Given this list of marker genes HADH, DNMT3B, SYTL1, ZC3H15, DIAPH1, WBP4, ANKRD36, ZFAND3-DT, MIB1, PGGHG, ZNF512B, OTUD4, EEF1DP3, TMEM134, KLHL5, DVL1, PRKAR1B-AS1, AGFG2 (NCBI Gene Id 3268), PPP1R13B-DT, LMO4, ATP2B1 (ATPase plasma membrane Ca2+ transporting 1), USP3, ANKH-DT, C8G, RERE, LINC01686, CHAF1B, TMEM131, SLC66A2, TPTEP2, MSL3-DT, FBXO41, KCTD13, NKTR, FBXO6, KCNMB4, RAC1, ZBTB7A, ALAD, GTF2H5, KIFC3, SPATA20, ACADM, ARL3 (NCBI Gene Id 403), ZYX, NSD3, DMAC2L, NELFB, NFE2L2, STYX, FCHSD2, TP53BP1, IP6K1, FAM120AOS, CHMP4B, TRAPPC8, VARS1, ACTR10, RASSF1, CHCT1, ORAI1, DRAM1, PDIA6, SPOPL, NAB1, ARHGAP31-AS1, EFHC1, IFNGR2, SEPTIN7, NFATC1, TRIB1, LYRM1, N4BP2L1, KLF2-DT, HIF1A, LMAN1, ANKEF1, POFUT1, CCDC42, PGK1, BTBD1, GSK3B, METTL25B, GLUD1, UBXN1, CDK13-DT, POLD3, SH3BP1, IER3-AS1, CISD3, DGKD, STX4, NQO2, KEAP1, BMP2K-DT, FBXW8, EPS8L2, SOCS5, BNIP2, CRAMP1, PDGFA, RCN2, SMAD3, AP2B1, ATP2A2, TIGD1 (NCBI Gene Id 200765), SLCO4A1, ERO1A, PIGX, CHCHD7 (coiled-coil-helix-coiled-coil-helix domain containing 7), UPP1 (uridine phosphorylase 1), PKMYT1, PANK2-AS1, SH3GLB2, PFN4, LINC01116, TFAM (transcription factor A, mitochondrial), FDX1, INTS11, KRI1 (NCBI Gene Id 65095), DGLUCY (D-glutamate cyclase), NDUFV3, MED9, MICAL1, ORAI2, TIMP1, FNDC3A, DAP, MYADM, PHRF1, PTGES3, TNFSF14, ZNF330, PHF13, RBPJ, ZNF524, RBFOX2, ANTKMT, TVP23C, SNX8, RIC1, ENSG00000233230, LRP3, COL7A1, TXLNA, PPP1R18, DCUN1D3 (defective in cullin neddylation 1 domain containing 3), CAMSAP1, EBPL, SNAP29, POU2F2, FAM131B-AS2, TLK1, NUP43, TWSG1-DT, ZCCHC24, CEBPA, ATAD2B, CREB5, RNF187, TRIOBP, IQCG, TRG-AS1 (T cell receptor gamma locus antisense RNA 1), COA7, SCN8A, CDNF, MIR142HG (NCBI Gene Id 123466215), RAD52, B3GALNT2, PPP3CB-AS1, CHST12 (carbohydrate sulfotransferase 12), HEXIM1, C8orf33, PPP1CA, GPX4, ILRUN-AS1, ZNF488, ORC4, STK35, PLEC, GTF2IRD2B, CPLX1, RABGEF1, KLF10, RRAGC-DT, TMSB10, ELMO2, CLN6, GTF2E2, LAMP1, PIAS2, QSER1, RGCC, CDKN2B-AS1, ACO1, CCDC34, EEPD1, CACNA2D1, SETD5, DCAF7, SMURF2, BRCC3, ANLN, MIR378D2HG, GABPA, SMIM14, KDM5B, TDRD3 (tudor domain containing 3), XPO6, SMAD3-DT, ANXA7, GATAD2B, FAM118A, RSRC1, LIPT2-AS1, SIAH2, SLC35B2, MIER1, THRAP3, TADA3, KATNAL2, OGFOD3, LIMD2, TMCO3, TRADD, FAR1, DPYD, TOM1, HEBP2, HPCAL1, PDZD8, USP28, TENT5C-DT, FOXJ3 (forkhead box J3), KDM7A, KBTBD7, LRRFIP1, EXOC3-AS1 (NCBI Gene Id 116349), CYP2U1, SLC16A3, N4BP3, TENT5C, S100A10, CCT6P3, DYRK3, PSMD13, SPSB1 (NCBI Gene Id 80176), AFF4-DT, HSPA8, DAZAP1, MBOAT7, IGF2BP3, ILRUN, APLP1, SRF, DNAAF9, SLC9A3-OT1, ZNF740, CORO2A, DENND4A, USP12, DNAI4, EPS15, PTPRE, USP32, BCL9, METTL25, CCND1 (cyclin D1), MRPL51, INTS4, USP42 (NCBI Gene Id 84132), FRAT2, STAT1, NR1D2, PHF19, CREBL2 (cAMP responsive element binding protein like 2), DCAF11, PARK7, DNM1L, TPI1, MED14, CEP83-DT, PTPRA, GOLGA2, RAB8B, MIR4710, COPRS, GCLC, EEF1A1, UBE2Z, MPO, TMEM139-AS1, LRFN4, IREB2, NFKBIE, ZC3H14, CYP20A1, DUSP2, LIPT2, URB2, ARHGAP12, AHNAK, SH3GL1, BRF1, ABI2, QSOX2, ZMYM2, TMEM52, MYADM-AS1, CCND3, TLE5, HVCN1, FABP5P3, SLCO4C1, CCNT2, PHF7 (NCBI Gene Id 51533), PPP1R3E (protein phosphatase 1 regulatory subunit 3E), RERE-AS1, LINC01703, SRD5A1, CDK19, KPNA1, RAB35, EFEMP2, ENTPD6, COX5A, ARMH4, ANP32A, ARPC5L, ZNF654 (zinc finger protein 654), PSMD2, GNPNAT1, PTPN11, LYL1, TBC1D1, C9orf72, NUDT14, ITGB1, YES1, NRARP, MDK, TVP23C-CDRT4, PTGES2-AS1, LPP-AS2, EEA1 (early endosome antigen 1), SNAPC2, SENP6, ZNRF1, RIN3, PLEKHO2, PLEKHF2, HDAC5, ZNF425, SLC20A1-DT, ZNF557, USP38-DT, SNHG4, HMGA1, STK32C, CEBPB, SQLE, HACD1, MALT1, LINC03100, TDRD7 (NCBI Gene Id 23424), GXYLT1 (NCBI Gene Id 338841), PGP, SPTAN1, MTCP1, TBKBP1, MIR3181, PAK4, RHEB, MINDY2-DT, SLC23A2, METTL21A, MIR760, DENND5B-AS1, SET, ANKRD17-DT, SACS, GNAQ, PRKD3, FBXO45, ERI2, SFXN3, IMPDH2, DCUN1D2, NUDT3, LACTB2-AS1, GSDMA, SLC9A5, THUMPD3-AS1, ADAM15, CEMIP2 (cell migration inducing hyaluronidase 2), TPT1-AS1, ATP1A1, PRRC2A, CKB, DENND1B, MIR4479, GSTO1, TCP11L2, ERBIN-DT, DNAJB6, SPRY2, LHB (luteinizing hormone subunit beta), TCFL5, ATP5PD, BTG1, TGIF1, LMBR1, KMT5B (lysine methyltransferase 5B), RCAN3, ZNF395, SMIM14-DT, TMEM117, MAFF (NCBI Gene Id 23764), BBC3, ZDHHC17, NR3C1, MPP1, KCNK5, SETX, ERGIC1, PLIN3, BRD2, SLC48A1, DEGS1, SH2D3C, SYNGAP1, NREP, ZBTB1, ARRDC2, LRRC8B, BRAF, CMTM7 (NCBI Gene Id 112616), PUS7 (NCBI Gene Id 54517), DDI2, APPBP2, FZD2, NUDT4, METRNL, KBTBD2, PRPF4, SERGEF, SIVA1, RBM26-AS1, RMND5A, LINC01117, PTH2R, SEPTIN7-DT, FHIP2A, TFE3, SLC35E4, ZNF592, SPOPL-DT, TBCD, TRAM2, SPHK1, HNRNPL, CDK14, SYP, AKIRIN2, GTDC1, NHERF2, PCNT, MANEAL, BMP2K, HSPA14, TSEN34 (NCBI Gene Id 79042), CAMSAP2, SRR, PPP2R5A, CORO1B, ERLIN1, RICTOR, RNF19A, ARFGAP3, TBC1D13, GALNT1 (NCBI Gene Id 2589), GNG10, PDHA1, NXT1, SAMM50, PTGES2, FOXO6, MAP3K20, DYRK3-AS1, B3GNTL1, GSTA4, ECI2, MXRA7, HIC1, BCAP31, GSKIP, CNDP2, HLCS, MED22, KCTD7, ECE1, ZNF213, SLC36A4, FUOM, ENSG00000187186, NUP214, FJX1, IL13RA1, DONSON, PLEKHA3, RNF2, GADD45B, GM2A, MPG, MOCS2, H3-3A-DT, MPC1, C21orf58, MOSPD2, PER1, TRAM2-AS1, SLC2A1-DT, RAB39A, PJA2, PRPF39, CYLD, STAP2, F3, FPGT-TNNI3K, APH1B, NR2F6, PMPCA, GANAB, PTGS1, HSD17B6, LINC02918, ETS2, GPC1, CSRNP1, THAP2, ADGRG6, CENPN (centromere protein N), BZW1-AS1, ENSG00000277020, FAAP20, SNX33, GFER, LASP1 (LIM and SH3 protein 1), ASMTL, FZD5, CCNY, PDP1, SUN2, ATP5PF, MAP4K5, YWHAB, RPL7A, RN7SL254P, PIK3R1, UBXN2A, SMTN, ABHD6, SLC9A8, PURB, CEP112, GCLM, ELK1, VEGFA, ARFGEF2, ZNF341-AS1, ATP6V0A2, RPUSD1, FAM86FP, ATRN, LMNTD2, SF1-DT, NANOS3, GRAMD1A, XPO1, PRIM1, CBFB, TRIM62, SERAC1, SP1, GJA3, TIMM21, RHOG, DEPDC5, DLG4, OSBPL2, FUT11, PTBP2, TMEM123-DT, MIB2, RAB8A, GNB1-DT, ARMC2, PRKAG2-AS1, PLAGL2, TBC1D10A, CCDC91, ANKRD17, FAM174C, ALDH3A2, SMARCD2, SCAF8, PANK2, FAM47E, SLC1A4, RASSF8, PPFIA3, DGKE, KRCC1, CFD, VAPA, LINC00327, NAB2, CDK9, HHEX, MINDY2 (MINDY lysine 48 deubiquitinase 2), MICU1, MIR29B2CHG, NCR3LG1, ANKMY2, ENSG00000228395, PARP6 (NCBI Gene Id 56966), ST3GAL5, SSBP3, TAF6L, SQLE-DT, DSTYK, MBD5, REX1BD, REL, HTATSF1, TRIM44, CREBRF, SMG1P3, ARRDC1, PLBD2, SOS1, UBE2Q2, FMNL3, HOOK3, STAMBPL1, CDYL, TMEM170B, STARD9 (StAR related lipid transfer domain containing 9), EIF4H, VWA7, FAM193A, ARID1B, NTNG2, CELSR1, MRGBP, LINC00963, PSMC2, PRKRA, AMER1, BZW2, CCDC137P1, EPOR, CDK13, GSK3B-DT, NEMP1, NSUN2, ST6GALNAC6, MAP3K14-AS1, FAM83G (NCBI Gene Id 650803), PANK4, FGF18, PBX3, TCF7, GRIFIN, NEK6, TRAF1, COL6A4P1, HNRNPAB, PHETA1, DAGLA, MLF2, RINL, ARF5, NCOA2, LHX4, CLDN6, TMEM250, USP38, FGF5, CSNK1E, EHBP1L1 (NCBI Gene Id 254102), NALT1, KCNIP2, SLC7A2, CASP2, LINC02356, NRL, CDK17 (NCBI Gene Id 5128), C7orf50, MAP4K4, NEUROG2-AS1, VPS37B, VSIR, GRAMD1A-AS1, ETV3, R3HDM2-DT, OSBPL1A, NCAPG2, EGR1, ASXL2, PKM, ZNF667-AS1, TSPAN5-DT, ERN1, ZNF511 (zinc finger protein 511), PRXL2C, FANCB, RAB35-AS1, LUC7L3, NAIF1, TM4SF19-DYNLT2B, FAM3C, MAP3K1 (NCBI Gene Id 4214), RPL6, TPT1, SNAI1, RNF145, GLYCTK, IFT140, PLOD1, MIR3180-5, ITGA4, SHOX2, ZNF786, CDKN2AIP, PTGER2, CD72, LMTK2, GRHL1, CLDND1, PPHLN1, OLFM2, RBM26, SEMA3F, SETD3, MBD2, CIRBP, LRRFIP1P1, KDM5C, BAIAP3, DNAJC21, SCARB2, MBLAC2, WDR48, EIF4E2, FBRSL1, C21orf91, RALA, RASAL2 (RAS protein activator like 2), PABPC1, ZNF641, TMEM123, POLG, RABGAP1L-DT, RABGAP1L, SRXN1, SMG1, DPF1, ZNF667, ITPRIP, CDCA4, CERK, CDK6, MAPK8, NISCH, KDM4A-AS1, NFIB, ODC1, CATSPER1 (cation channel sperm associated 1), LMLN, FOXD1, RCOR1, TRAM1, BHLHE40, ECI2-DT, CPTP, H3-3A, NPAS1, GID8, RAB7B, AP1AR-DT, CERCAM, PALD1, CNIH3-AS2, PRKD3-DT (NCBI Gene Id 101929542), RASSF8-AS1, PDGFA-DT, MAP3K14, GDPD5, SPTBN4, DLEU2, SMCO4, ITGB1-DT, ZNFX1, ING2, EIF1B-AS1, NSD2, CPSF1, TMEM18, RNF103-CHMP3, CHAMP1, PBX2 (NCBI Gene Id 5089), MIR5684, PXN, TUT7, ITGB3 (integrin subunit beta 3), DNAJC2, MELTF-AS1, ANKRD50, ZDHHC12-DT, NUP188, MMUT, MRPL40, ASPSCR1, ZNF438, TBK1, KCTD2, KCTD13-DT, CARD10, CCDC106, SWI5, ENO1-AS1, FAM120A, SH3RF1, TM4SF19, SYNCRIP, ST3GAL3, PTBP3, IRF2BP2, CLPX, TJP2, C19orf25, TMCC1-DT, HPRT1, SLC25A32, SYNPO, RXRA, FBRS, ARHGEF26-AS1, WDR53, TMC6, MAPK1, RNA5SP155, ZNF511-PRAP1, MADCAM1, CIB1, PRPF39-DT, HIBADH, MIF4GD-DT, KMT2C, NIPSNAP1, PGM2, MANF, DYNC1I1, TRAF3, DTD1 (D-aminoacyl-tRNA deacylase 1), DHX35, BICDL1, TWSG1, ZNF446, MTDH, ZCWPW1, CHRAC1, KRT8, GPLD1, ZSWIM6, CNOT3, HIRA, SLC16A1, TMEM241, YAF2, AFG3L2, NUB1, AVPI1, NEDD4L, CAPRIN2, LIPT1, FAF1, ATL1, KLHL22, PPP1R13B, FAM228B, ZNF584, BMPR2, TNFRSF12A, AKAP11, RWDD3-DT, TXNDC16, ELF4, FBXO15, WNK1, NEAT1, SGK1, RNH1, BTG2, DCXR-DT, PAQR8, STUB1-DT, ANKH, CABIN1 (NCBI Gene Id 26293), SLC25A10, STAU2, GASAL1, POLI, TRIM37 (NCBI Gene Id 4591), SPOCD1, SNX30-DT, RRAGC, LEMD1, ELF1, BTRC, GFI1, SH3TC1, PKD1, PTBP1, SKIL (SKI like proto-oncogene), ZMIZ1-AS1, SIRT1, RHBDF2, INPPL1, SEC22C, USP27X-DT, STK24, EIF1B, ABCD3, BAIAP2, FRG1-DT, SMG1-DT, SMARCD3, NUMB, PAK1, DMWD, TUBA1C, PTMS, PPM1J-DT, DNAJC27, OTUD5, CARNMT1, FBXO11, DHX35-DT, RN7SL521P, EEIG1, TRIM3, RPS6KA5, YY1AP1, SLC25A25, ADM2, HDAC7, CISTR, CACNA2D4, NECTIN1-DT, IL6R, LIMS1, NDUFV2, NECAB3, FLJ38576, CCDC57, ESYT2, CAMSAP1-DT, PDLIM7, UBE2J1, GSPT1, TPM4, EEF2KMT, KIF2A, ACACA, NOP56, APLP2, RASSF7, TXNL4A, RBM39, PUSL1, MATCAP1, RFX3, SBNO2, SRGAP1, TDRKH, DSTN, NXN, MAN1A2, RAD23B, TNIK, CIMAP1B, EXOC6, MACIR, BAG6, DCAF6, HSP90AA1, CC2D1B, UNC119B, FPGT, WDFY2, DENND1A, TMEM158, HMGN2 (high mobility group nucleosomal binding domain 2), PCBD2, GAREM1, KLF16, IPO13, SF1, SPATA1, DNPEP-AS1, TTC3, ING2-DT (ING2 divergent transcript), TMEM91, AGO2, PPARG, DGKQ, FBXW5, CENPQ, H6PD, AKT2, PHLDA2 (NCBI Gene Id 7262), ITPK1, CCNY-AS1, ZNF652, MED15, GATAD2A, TTL, SNORD12C (NCBI Gene Id 26765), DHODH, GNG5, ZNF48, TCF4, DNAAF1, CNIH3, RNF103, LINC03044, SLC38A10, ZNF410, TOP6BL, PCMT1, AFTPH-DT, BICRA, TOP2B, RNF24, PLAG1, UBE2I, BTG1-DT, PARD6B, BFSP1, PRKAA1, E2F3 (E2F transcription factor 3), C6orf47, ERBIN, PI4KA, USP34-DT, NT5DC3 (NCBI Gene Id 51559), ITGB8, SKI, AMN1, DIDO1, PLSCR3, BICRA-AS2, DNAJC13, FOSL2, HIVEP1, GUK1, MLLT10, C1orf220, CORO1C, LAMC1, APPBP2-DT, SSX2IP (SSX family member 2 interacting protein), VASP, FIZ1, SNX30, USP11, TBC1D10C, KLHL8, TFEB, SMPD1, ZFP62, CPM, STIM2, B3GNT5, MIDN, WDR1, MTM1, PLA2G15, DSE, CCDC59, FGD5-AS1, MYCBP2, CLIP2, OTUD1, HS6ST1, SP4, ATP11B, SARS1, ACTN1-DT, NCAPD2, SMG6, TSGA10, HCP5, GPATCH8, MEPCE, CAPN7, GCC2-AS1, ME1, MIA3, AP3D1, CEP131, CXADR, ANGEL1, CD164, YY1, PIGP, ENTR1, PRIMPOL, STAU1, CTDSP1, NGFR, SSB, LINC01881, PLAU, TMEM50B, RBBP7, PLCD1, C1QL4, HEXD, IZUMO4 (IZUMO family member 4), CSAD, MGRN1, LYRM9, PRPSAP2, NOSIP, CMC4, SYDE2 (NCBI Gene Id 84144), POLM, SAMD11, DOLK, UGCG, CEBPB-AS1, DNAJC27-AS1 (DNAJC27 antisense RNA 1), CCSER2, MAD2L2, MOB3A, MOCS2-DT, RWDD3, LCOR, AKT1, KLF13, ULK3, FAM76B, NOXA1, ADRM1, NECTIN1 (NCBI Gene Id 84853), NFXL1, POLG-DT, NFYC, LYRM4, EEF1AKMT3 (NCBI Gene Id 25895), CARM1, SMURF1, CLTC, CERS2, IFT88, GALNT7-DT (NCBI Gene Id 101930370), ATP9B, TGFB1, BTG3-AS1, GVQW3, TTLL12, ZC3H12D, TLNRD1, ADAM17, SNX4, AFF4, PIWIL4, AASDHPPT, CCNA1, PRKAG2, CD83, ANKS6, IDUA, RASAL2-AS1, RBFA, ISG20L2, GKAP1, ARHGAP25, ERICD, ACTN1, KMT5C, GAPDH, MPC2, RPS2P32, STRN, RCC2, C18orf21, PDPR2P, STUB1, RBM27, UBAC2, SATB2, LINC01932, DAP3, RNASET2, TRGV6, BLMH, AP1AR, CEP83, APC2, GGA1 (golgi associated, gamma adaptin ear containing, ARF binding protein 1), GCNT1, ACTL6A, MATR3, CBX2, SVIP, FAM136A, ZBTB33 (NCBI Gene Id 10009), STRADA, CUL1, UBAC2-AS1, ENSG00000215022, CPSF6, PICALM, KDM2A, MATN1-AS1, BAIAP2-DT (BAIAP2 divergent transcript), POLR3G, ZC3H12A (NCBI Gene Id 80149), NPEPL1, L2HGDH, RASSF5, ARFGEF3 (ARFGEF family member 3), REV1, SPACA6, PDIA4, CNGA1, BCL3, METAP1, CHTF18, RASGRP2, FOXP1, ODC1-DT, PACS1, UNC93B1, ZFAND3, ITM2B, PDHB, SLC25A40, EXOC3, MAP1A, ARHGEF26, MRPL55, HSDL1, HSPG2, CCSAP, PJVK, CBX7, ENSG00000282564, FAM78A (family with sequence similarity 78 member A), NR2C2, FRS3, LMNA, BCAR3, PCGF5, LMF1, PLAUR, RNF38, USP34, NUP153, STK24-AS1, INF2, CDKN2A, ZBTB18, ATP8A1, BRWD1, SAMD8, GPR157, SLC9A3-AS1, CMIP, TMCC1, PRKAR1B, HECTD2, MAN1C1, IRS2, ZSCAN5A, ST3GAL5-AS1, DDX59 (DEAD-box helicase 59), CENPW, RAB11FIP4, TMEM18-DT, FAM98C (NCBI Gene Id 147965), ATP11B-DT, CMC2, PSIP1, NINJ2-AS1, PLEKHO1, MIR4674, RC3H2, C17orf67, ARPC4, KLF3 (NCBI Gene Id 51274), SNX18, KBTBD3, DCXR (dicarbonyl and L-xylulose reductase), EIPR1, PRR12, MIF4GD, RAB20, FBXW11, MBD6, EPHB6, DLX2-DT, WDR44, MHENCR, PKNOX1, DUSP22, INTS10, TUBA1A, SFXN2, SLF2, DPY19L1, ARFGAP2, STX11, B4GALT1, THAP12, GNB1, CNP, CAMTA1 (calmodulin binding transcription activator 1), MNT, TSPAN5, MEGF8, LINC01010, REL-DT, IRF2-DT, ZNF652-AS1, BTG2-DT, RNU6-1, RBX1, SLC12A2-DT, RTF2, STX17, P4HTM, CNOT4 (NCBI Gene Id 4850), ABHD3, CRELD1, PTP4A2, MSL3, AEBP2, AHCYL2, SIRT3, ARAP2, HDGFL2, YBX3, DTNB, KLHL21, VAV1, MICALL1, EXD3, ZNRF3, MCRIP2, MACF1, FARP2, RFX3-DT, RAB11A, LPIN2, SCAI, ZDHHC12, RNF168 (NCBI Gene Id 165918), HACE1, RNF170, HCG27, BRD4, GPR137C, EDEM1, HTT-AS, GPAM, ZSCAN5A-AS1, USP46-DT, RPS6KA2, SERTAD2, TUBGCP2, PODXL, RAD54L, ZNF280B, KLF6, HECTD1, PDZD7, PPIB, TMBIM6, FAM168A (family with sequence similarity 168 member A), ZFP14 (ZFP14 zinc finger protein), CEP57, KIAA1671, ADGRB2, MFN2, REST, PYCARD, DENND5B, MARCKSL1P2, GDPGP1, DNPEP, KRAS, RNPEPL1, BAP1, TAF5L, FAR1-IT1, LYSMD3, CHIC2, LINC01144, ZBTB25, SGMS2, SP3, MAD1L1, DNAJC7, RUNX1, ARPC4-TTLL3, CALM1, PRPSAP1, ZFAS1 (NCBI Gene Id 441951), USP9X, PPP2R5C, MIR4515, SMIM29, LRRK2, DUSP5, RASSF1-AS1, YTHDF2, LRRC1, HADHA, ALDH5A1, ABCD1, CDH24, ABR, TUBB2A (NCBI Gene Id 92919), RFTN1, SLC35F2, PDXK (NCBI Gene Id 8566), NOTCH1, TMEM243, EOGT-DT, HAX1, FBXL8, KDM1A, CDKN2C (cyclin dependent kinase inhibitor 2C), SLC16A1-AS1, FAM169BP, CCNK, CDC26, KDM7A-DT, LRRK2-DT, CERNA1, DHRS13, ACTG1, SNHG7, CCNI, AFTPH, CD99, SLC41A2, ZNF837, LRRC27, CDC42SE1, ATP8A1-DT, FRG1, SLC37A4, KTN1, ING5, CEBPA-DT, SLC12A2, NINJ1, FLOT1, ZNF213-AS1, LSM14B, PTMA, CASP3 (NCBI Gene Id 836), CASP9, DYNLL2-DT, SLC4A2, PPP2R5CP, DBF4, BZW1, TMEM87B, PPM1J, BAZ1A-AS1 (BAZ1A antisense RNA 1), TMTC4, RBM38, TLE4, MIR6821, SLC25A15, LINC01460, RMC1, SRSF5, ATP8B2, MRC2, RING1, CCNT1, DYRK2, UBE3A, SMS, CDYL-AS1, USP27X, ODAD1, SH2B2, FARS2, APPL1, KLHDC2, ACADVL, ACSL4, HERC4, TTC39C, KTN1-AS1, NQO2-AS1, SLC25A6, TDRKH-AS1, LRRIQ3, USP25, SEH1L, CUL3, MLST8, EOGT, IRF2, EZH2 (enhancer of zeste 2 polycomb repressive complex 2 subunit), CAND1, SMG1P2, ZNF480, CHSY1, ATP1B1, TPTEP1, PIAS1, ARL5A, SELENOM (NCBI Gene Id 140606), CHD9, DDX59-AS1, GCSH, DCAF13, BTBD6, here is a description of the gene set: from publication Yevshin I, Sharipov R, Kolmykov S, Kondrakhin Y, Kolpakov F (PMID 30445619) Genes containing one or more binding sites for (NAB2) in their promoter regions (TSS -1000,+100 bp) as identified by GTRD version 20.06 ChIP-seq harmonization. species: Homo sapiens Human Gene Set: NAB2_TARGET_GENES